Given this list of marker genes NFKB1 (NCBI Gene Id 4790), MAFK, EP300, NFE2L2, RELA, MYC, NOTCH1, CREBBP, here is a description of the gene set: Human Gene Set: REACTOME_REGULATION_OF_NFE2L2_GENE_EXPRESSION Regulation of NFE2L2 gene expression species: Homo sapiens